Given this list of marker genes MFAP4, SLC37A2, RBP1, HEY1, C16orf54, OTULINL, LSS, CA6, MAFB, AHR, FAM111A, ALDH1A3, PDGFRA, ACAN, SCD, DOCK2, LYL1, STC2, NNMT, MCF2L, CELF2, INSIG1, RAB3IL1, PHIP, UQCC6, FOXG1, PTPN18, FLI1, VWA5A, NR4A2, CCN5, RPL39L, here is a description of the gene set: Human Gene Set: PLASARI_TGFB1_SIGNALING_VIA_NFIC_10HR_DN species: Mus musculus from publication Plasari G, Calabrese A, Dusserre Y, Gronostajski RM, McNair A, Michalik L, Mermod N (PMID 19752192) Genes down-regulated after 10 h of TGFB1 stimulation in MEF cells (embryonic fibroblast) with NFIC knockout vs wild type MEFs. Transforming growth factor beta (TGF-beta) and platelet-derived growth factor A (PDGFAlpha) play a central role in tissue morphogenesis and repair, but their interplay remain poorly understood. The nuclear factor I C (NFI-C) transcription factor has been implicated in TGF-beta signaling, extracellular matrix deposition, and skin appendage pathologies, but a potential role in skin morphogenesis or healing had not been assessed. To evaluate this possibility, we performed a global gene expression analysis in NFI-C(-/-) and wild-type embryonic primary murine fibroblasts. This indicated that NFI-C acts mostly to repress gene expression in response to TGF-beta1. Misregulated genes were prominently overrepresented by regulators of connective tissue inflammation and repair. In vivo skin healing revealed a faster inflammatory stage and wound closure in NFI-C(-/-) mice. Expression of PDGFA and PDGF-receptor alpha were increased in wounds of NFI-C(-/-) mice, explaining the early recruitment of macrophages and fibroblasts. Differentiation of fibroblasts to contractile myofibroblasts was also elevated, providing a rationale for faster wound closure. Taken together with the role of TGF-beta in myofibroblast differentiation, our results imply a central role of NFI-C in the interplay of the two signaling pathways and in regulation of the progression of tissue regeneration.